The following is a description of a gene set: Human Gene Set: GOBP_NEGATIVE_REGULATION_OF_GLOMERULAR_FILTRATION studied in species Homo sapiens Any process that stops, prevents, or reduces the frequency, rate or extent of glomerular filtration. Glomerular filtration is the process whereby blood is filtered by the glomerulus into the renal tubule., and this is the list of marker genes: GJA5, TTR, F2R, PTPRO, CYBA